Given this list of marker genes SUSD1, IL2RB, THBD, TSPAN33, LNX2, DYRK3, SH3TC2, ZNF703, RYBP, MRPS7, UBE2H, SNX5, RASD1, ANKRD37, DDIT3, FAM117B, ZCCHC9, ARID3B, FKBP11, SNAP29, LRRC73, PLEK, KCTD17, NEURL2, SLC25A33, APP, IER2, IL6R, PCYT1A, BRWD3 (NCBI Gene Id 254065), PNPLA8, TBX21, GPR132, TNNI2, LGALS1, S100A6, TXNDC16, ST3GAL5, SH3PXD2A (NCBI Gene Id 9644), LIN54, HAVCR1, CDC25B, SYNE3, HMGCS1, UBL3, PHF13, PICALM, CRIP1, SPRED1, CRAT, SLPI, ATF3, ABI1, RAB9A, BAIAP2L1, POLR1D (RNA polymerase I and III subunit D), METRNL, CKB, SNX25, GNA13, JUNB, PPP1R2P1, KCTD1, MAFG, PITPNA, CUL2, PKP4, PI4K2A, ATP6V1E1, INSIG1, NSA2, FAM107B, TMEM176A (NCBI Gene Id 96710), IGBP1, ASPH, KDM6B, PIK3AP1, TMEM176B, CLDND1, LDLR, APOBR, SKIL, RTCA, ARHGAP15, MFSD14A, CASS4, CYP51A1 (NCBI Gene Id 1595), SYNGR2, GNG12, PTGER1, MARCHF7, UBE2G1, LCP2, SH2D1B, HEXIM1, CD2, NRBP1, EMP3, ST8SIA6, DAP, HIVEP3, BCL2L11, MEX3B, TBC1D14, ANXA2, TMEM11, GRB7, EIF4EBP1 (eukaryotic translation initiation factor 4E binding protein 1), COQ10B, EVA1B, ZNF830, RALA, UBE2B, FGF18, PLS1, GSTT2, TPPP, LIPG, ATP6V0D1, RNF2 (NCBI Gene Id 6045), TEN1, PDK3, TPP2, HERPUD1, FAS, CHST7, F2RL1, TUBB2A, TUBB3 (tubulin beta 3 class III), PPP1R11, SH3BP5, ITGA6, RRAGC, UQCRFS1, BST2, HIF1A, BBS9, HNRNPH2, AICDA, S100A10, UNC119B, SKAP2, VAT1, VPS35, SYT11, DNM3, OTULIN, FXYD5, ZBTB2, MYADM, NEK7, ATXN7L1, GPCPD1, UPB1, SPG21, ANKRD44, CD86, GLIPR2, TMEM120B, TM4SF5, BCL2L14, ERP44, TATDN2, DHRS3, ENC1, PLEKHB2, CENPA (NCBI Gene Id 1058), PGPEP1L, ZBED6, DUSP5, ARL4C, EDEM1, TGIF1, ATP6V1A (NCBI Gene Id 523), DNAJB2, CEP112, RIPOR2, CEP43, IFITM3, TMED5, NKIRAS2, PCMTD1, SPN, BSND, DAD1, PADI2, SRGN, GPD1L, RAB30, LASP1, LRRC56, ASAP1, C19orf53, PACSIN1, MAP4, KDM6A, CHD7, KCNK6, ACTG1, PPM1G, here is a description of the gene set: Genes down-regulated in macrophages with SOCS3: untreated versus IL6 for 100min. from publication Lang R, Pauleau AL, Parganas E, Takahashi Y, Mages J, Ihle JN, Rutschman R, Murray PJ (PMID 12754506) species: Homo sapiens Effects of SOCS3 on the transcriptional response of bone marrow-derived macrophages to IL-6. Fetal liver cells from SOCS3+/+ or SOCS3-/- embryos were used to reconstitute recipient mice. Donor derived bone marrow from these mice was differentiated to macrophages. Macrophages were either unstimulated, or stimulated for 100 or 400 minutes with 10 ng/ml IL-6. Human Gene Set: GSE411_UNSTIM_VS_100MIN_IL6_STIM_SOCS3_KO_MACROPHAGE_DN